The following is a description of a gene set: Genes having at least one occurrence of the highly conserved motif M84 RGTTAMWNATT in the regions spanning 4 kb centered on their transcription starting sites. This matches the TCF1 transcription factor binding site V$HNF1_01 (v7.4 TRANSFAC). Human Gene Set: RGTTAMWNATT_HNF1_01 from publication Xie X, Lu J, Kulbokas EJ, Golub TR, Mootha V, Lindblad-Toh K, Lander ES, Kellis M (PMID 15735639) Comprehensive identification of all functional elements encoded in the human genome is a fundamental need in biomedical research. Here, we present a comparative analysis of the human, mouse, rat and dog genomes to create a systematic catalogue of common regulatory motifs in promoters and 3' untranslated regions (3' UTRs). The promoter analysis yields 174 candidate motifs, including most previously known transcription-factor binding sites and 105 new motifs. The 3'-UTR analysis yields 106 motifs likely to be involved in post-transcriptional regulation. Nearly one-half are associated with microRNAs (miRNAs), leading to the discovery of many new miRNA genes and their likely target genes. Our results suggest that previous estimates of the number of human miRNA genes were low, and that miRNAs regulate at least 20% of human genes. The overall results provide a systematic view of gene regulation in the human, which will be refined as additional mammalian genomes become available. studied in species Homo sapiens, and this is the list of marker genes: KRT25, GRB7, LPAL2, KMT2A, HNF1B, LCT, SLC25A45, GOLT1A, COL16A1, COL9A1, PDLIM5, KCP, F13B, CNTD1, COA3, EGR1, ZBTB4, NCKAP5, ARHGAP24 (Rho GTPase activating protein 24), EEPD1 (NCBI Gene Id 96007), SGK2, TINAG, THOC6, NFE2L2, SLC12A2, NRP2, SLC5A12, GC, GLRA2, HOXD4, USP3, DMD (NCBI Gene Id 548327), ACSL4, HOXA10 (NCBI Gene Id 3206), MITF, FGFR4, HNF1A, LINC00671, ANXA13, IGFBP1, MYRF, LIPC, HOXC6, PLA1A, RTN4, CARMIL3, POLR2A, CYP26A1, THAP11, SLC23A1 (NCBI Gene Id 9963), CDH16, HGFAC (NCBI Gene Id 3083), SLC17A4, BCL9, G6PC1 (glucose-6-phosphatase catalytic subunit 1), APOM, DZIP1L, UGT1A6, HOXC4, SERPING1, PLG, SLC17A2, HCFC1R1 (NCBI Gene Id 54985), RBMS1, NR5A2, HABP2, DLX1 (distal-less homeobox 1), RNF186, TTR, BMI1, AGT, NPAS2, CLDN19, CFI